The following is a description of a gene set: Escherichia Map to CDC42 signaling pathway. Pathway ID: N01096. Pathway type: Pathogen. Pathway class: nt06135 Cytoskeletal regulation (viruses and bacteria). Pathway Definition from KEGG: Map -> CDC42 -> WASL -> ARP2/3 -> (ACTB,ACTG1) species: Homo sapiens Human Gene Set: KEGG_MEDICUS_PATHOGEN_ESCHERICHIA_MAP_TO_CDC42_SIGNALING_PATHWAY, and this is the list of marker genes: ARPC2, CDC42, ACTR2 (NCBI Gene Id 10097), ACTG1, ACTB, ARPC5, ACTR3, ARPC1A, ARPC4, WASL, ARPC3, ARPC5L, ARPC1B